The following is a description of a gene set: studied in species Homo sapiens Human Gene Set: GOCC_CHYLOMICRON A large lipoprotein particle (diameter 75-1200 nm) composed of a central core of triglycerides and cholesterol surrounded by a protein-phospholipid coating. The proteins include one molecule of apolipoprotein B-48 and may include a variety of apolipoproteins, including APOAs, APOCs and APOE. Chylomicrons are found in blood or lymph and carry lipids from the intestines into other body tissues., and this is the list of marker genes: APOBR, APOA5, APOC2, APOC3, APOA2, APOB, LSR, APOA1, APOE, LPL, APOC1, APOA4, APOH